Given this list of marker genes Tigar, Zc3h12a, Cbr1b, Hk2, Clcn3, Cyba, Eif5a (NCBI Gene Id 28059), Hbp1, Crp, Hspd1, Gadd45a, Pdgfb, Agtr1a, Foxm1, Hif1a, Snca, Zfp13, Mmp3, Brca1, Ager, Fyn, Ctns, Mapk14, Mapt, Mt3, Atg5, Ptgr1, Stat3, Park7, Nox4, Akr1c18, Mfn2, Rhoa, Sirt1, Cryab, Birc2, Duoxa1, Adcy10, Abcd2, Parl, Sphk2, Fpr2, Mpv17, Tyrobp, Ripk3, Alox12, Elavl1, Tlr4, Acod1, Cd36, Ngfr, G6pd2, Bco2, Mycn, Coq7, Lcn2, Pikfyve, Nnt, Itgb2l, Abcd1, Rnf41, Aldh2, Slc5a3, Hdac4, Pink1, Ptger4, Mpv17l, Ndufc2, Ins1, Sod1, Sirt3, Foxo3, Shc1, Eif6, Gch1, Dcxr, Nfe2l2, Fbln5, Sirt2, Noxa1, Tgfb1, Cxcl1, Tfap2a, Grin1, Hvcn1, F2rl1, Vdac1, Syk, Xdh, G6pdx, Cflar, Akt1, Thbs1, Prdx2, Bcr, Lrrk2, Cd177, Pdk3, Duoxa2, Dhfr, Insr, Alox5, Tgfbr2, Coa8, Gnai3, Rab27a, Itgam, Tusc2, Birc3, Acp5, Abcb7, Il18, Tnf, Esr2, Egfr, Ncf2, Cyp1b1, Sirt5, Ptk2b, Plau, Pax2, Sod2 (NCBI Gene Id 20656), Foxo1, Clec7a, Cdkn1a, Trp53, Plin5, Arg2, Trim30a, Ripk1, Gstp1, Il4, Gnai2, Romo1 (NCBI Gene Id 99750), Prkcd, Ppara, Tlr6, Lep, Ccn6, Slc25a33, Ogt, Cbr1, Map3k7, Prcp, Adgrb1, Ucp1, Pon3, F2, Tspo, Ins2, Plcg2, Pid1, App, Prkn, Nqo2, Nox1, Itgb2, Grb2, Pdgfrb (platelet derived growth factor receptor, beta polypeptide), Agt, Ier3, Arf4, here is a description of the gene set: Any process that modulates the frequency, rate or extent of reactive oxygen species metabolic process. Mouse Gene Set: GOBP_REGULATION_OF_REACTIVE_OXYGEN_SPECIES_METABOLIC_PROCESS studied in species Mus musculus